The following is a description of a gene set: studied in species Homo sapiens from publication Cancer Genome Atlas Research Network (PMID 18772890) Genes significantly mutated in 91 glioblastoma samples. Human cancer cells typically harbour multiple chromosomal aberrations, nucleotide substitutions and epigenetic modifications that drive malignant transformation. The Cancer Genome Atlas (TCGA) pilot project aims to assess the value of large-scale multi-dimensional analysis of these molecular characteristics in human cancer and to provide the data rapidly to the research community. Here we report the interim integrative analysis of DNA copy number, gene expression and DNA methylation aberrations in 206 glioblastomas--the most common type of adult brain cancer--and nucleotide sequence aberrations in 91 of the 206 glioblastomas. This analysis provides new insights into the roles of ERBB2, NF1 and TP53, uncovers frequent mutations of the phosphatidylinositol-3-OH kinase regulatory subunit gene PIK3R1, and provides a network view of the pathways altered in the development of glioblastoma. Furthermore, integration of mutation, DNA methylation and clinical treatment data reveals a link between MGMT promoter methylation and a hypermutator phenotype consequent to mismatch repair deficiency in treated glioblastomas, an observation with potential clinical implications. Together, these findings establish the feasibility and power of TCGA, demonstrating that it can rapidly expand knowledge of the molecular basis of cancer. Human Gene Set: TCGA_GLIOBLASTOMA_MUTATED, and this is the list of marker genes: PIK3CA, RB1, ERBB2, PIK3R1, TP53, EGFR, PTEN, NF1